The following is a description of a gene set: part of: Inflammasomes studied in species Mus musculus electronically inferred by orthology from the curated human pathway This event has been computationally inferred from an event that has been demonstrated in another species.<p>The inference is based on the homology mapping from PANTHER. Briefly, reactions for which all involved PhysicalEntities (in input, output and catalyst) have a mapped orthologue/paralogue (for complexes at least 75% of components must have a mapping) are inferred to the other species. Reactome Pathway: The NLRP3 inflammasome, and this is the list of marker genes: Txn1, Panx1, Sugt1, Pycard, Mefv, Nlrp3, Pstpip1, P2rx7 (purinergic receptor P2X, ligand-gated ion channel, 7)